Given this list of marker genes MAFK, ABCF2, ABCC1, ABCG2 (NCBI Gene Id 9429), NFE2L2, EP300, CREBBP, ABCC3 (ATP binding cassette subfamily C member 3), here is a description of the gene set: NFE2L2 regulating MDR associated enzymes species: Homo sapiens Human Gene Set: REACTOME_NFE2L2_REGULATING_MDR_ASSOCIATED_ENZYMES